Given this list of marker genes AKAP12, C5AR2, CCR2, MIR195, APP, PIK3R1 (NCBI Gene Id 5295), IL27RA, AGER, CYBB, TLR9, ZBTB20, ADIPOQ, BCL3, ADAM8, VSIR, CD14, FXR1, CD274, FCGR3A, CYBA, LILRA2, UBE2J1, LTF, CLEC4A (NCBI Gene Id 50856), IFNG, AZU1, ABCC8, MYD88, AXL (NCBI Gene Id 558), ELF4, MIR105-1, DICER1, EPHB2, MIR920, MIR185, FOXP1, GHRL, POMC, OAS2, DHX9 (DExH-box helicase 9), GPR18, IL6, MC1R, LILRB4, LILRB1, LEP, IL33, LGALS9, HMGB1, SELENOS, HDAC2, FZD5, TNFAIP3, TREM2, STAT3, SPON2, OAS1 (NCBI Gene Id 4938), CD47, CX3CR1, LRRK2, HAVCR2, SYT11, MIR140 (microRNA 140), NLRC3, SPN, AKAP8 (A-kinase anchoring protein 8), PARK7 (Parkinsonism associated deglycase), ORM1, GSTP1, ILRUN, SYK, TIRAP, SETD4, TLR4, FCER1G, HSF1, FOXP3, ADAM17, RARA, ARRB2, ARFGEF2, BPI, GPNMB, IL4, SPHK2, RIPK1, IFIH1, MAVS, CACTIN, TYROBP, ARID5A, ARHGEF2, MIR6869, TWIST1, MIR101-1, MIR130A, CCL19, ACP5, C1QTNF4, HLA-E, NOD2, TSPO, NFATC4, IL12B, SASH3, NFKBIL1, CD36, MIR144, TNFRSF8, HDAC3, MIR98, LPL, MMP8, MIR125B1, ZFP36, JAK2, GAS6, PTPRC, CCL3, SIRPA, TREX1, IL1A, MIR708, MIR181A2, LILRA5, OAS3 (2'-5'-oligoadenylate synthetase 3), CARD9, LBP, IFNGR1, CX3CL1, LY96, CD33, IL10, ISL1, TMEM106A, TGFB1, FCGR1A, TLR6, PTPN11, PLCG2, IL17F, RIPK2, CIDEA, MIR488, LILRA4, TICAM1 (TIR domain containing adaptor molecule 1), MIR657, CLEC7A, FCGR1BP, MIF, MIR361, CHRNA7, SELENOK, PTPN22, IRAK3, TLR1, NR1H4, PSEN1, IL17A (NCBI Gene Id 94918), MIR149, ZC3H12A, FCGR2B, HSPB1, RAD21, PTPRJ, FRMD8, MIR27B, PYCARD, TLR2, GHSR, PF4, BCL10, DDT, DEFB114, MIR204, SLAMF1, ARG2, BTK, ORM2, RIGI, PTPN6, THBS1, MAPKAPK2, FADD, FCGR2A, MIR132, CD86, TLR3, ERRFI1, CD2, TRIM27, FCGR2C, IL23A, ADAM10, ANGPT1, IGF1, NRDC, IL37, CLU, WNT5A, MIR206, NOD1, here is a description of the gene set: Human Gene Set: GOBP_TUMOR_NECROSIS_FACTOR_SUPERFAMILY_CYTOKINE_PRODUCTION species: Homo sapiens The appearance of any member of the TNF superfamily due to biosynthesis or secretion following a cellular stimulus, resulting in an increase in its intracellular or extracellular levels.